Given this list of marker genes MRAS, SHOC2, BRAF, PPP1CC, YWHAB, PPP1CB, ARAF, RAF1, here is a description of the gene set: part of: Oncogenic MAPK signaling A complex of MRAS, SHOC2 and the phosphatase PP1 contributes to the activation of RAF proteins by removing an inhibitory phosphorylation that mediates binding to 14-3-3 (also known as YWHAB) proteins. Activating and inactivating mutations in each of the components of this dephosphorylating complex have been identified in RASopathies as well as at low frequency in some cancers. Reactome Pathway: Signaling by MRAS-complex mutants studied in species Homo sapiens